The following is a description of a gene set: species: Homo sapiens Any process that modulates the frequency, rate or extent of a cellular response to stress. Cellular response to stress is a change in state or activity of a cell (in terms of movement, secretion, enzyme production, gene expression, etc.) as a result of a stimulus indicating the organism is under stress. The stress is usually, but not necessarily, exogenous (e.g. temperature, humidity, ionizing radiation). Human Gene Set: GOBP_REGULATION_OF_CELLULAR_RESPONSE_TO_STRESS, and this is the list of marker genes: DNAJC7, SLC38A2, RMI2, SPRED1, SYVN1, BRCA2, INSIG1, TIMELESS, SIRT6, SMARCD1, MDM2, HNRNPK, ANKRD1, SELENOS, PINK1, COMMD1, SEMA4C, FUT8, PTTG1IP, RAD52, POLH, RNF126, VPS72, ATXN3, PUM2, TEX15, NCK1, MTOR, PAGE4, TP53, PMAIP1, LRIG2, CD44, UFL1, ADCY8, DUSP10, MAP2K1, DDIAS, CD74, NR1H2, ARL6IP5, WAS, RTCA, BCL2L1, EPC2 (NCBI Gene Id 96643), TADA2B, TAF9, H2AX, ERP29 (NCBI Gene Id 10961), UBQLN1, PELI1, XRCC1, COPS3, MYC, PPP4R2, POT1, EP400, DYRK1A, PYHIN1, PNKP, INO80C, PRDX1, ACTL6B, PTN, TMX1, MBTPS2, LETM1, MRNIP, PIAS4, TAF6, THY1, RNFT1, RPA2, WRAP53, ATRIP, YBX3, PAQR3, EIF4G1, WFS1, SLF1, RNASEH2B (NCBI Gene Id 79621), PTGS2, NR1H3, HMGB1, CAV1, EYA4, BID, TIFAB, TERF2, CARD9, RNF8, NTRK3, TAF7, KAT5, TFPT, TAOK1, MAP3K20, MMP14, PPP4R3C (NCBI Gene Id 139420), KAT2A, DDX11, RNF168, STUB1, BCL7B, SKIL, BCL7C, ATAD5 (ATPase family AAA domain containing 5), SUPT20H, PRRX1, PLA2R1, MAGEA3, SMCHD1, ERCC6, FANCB, BRD7, CD36, ARID1A, FICD, UBQLN4, STK25, KIAA0319, SMARCC1, DNAJC2, ERN1, KDM1A, DEK, DNAJB6, PARP3, HELQ, FEM1B, FBH1, PML, TRIM28, ING3, SVIP, SHLD1, RECQL5, SERINC3, GSTP1, C11orf54, HDAC6, MID1, BDKRB2, MUC1, BAX, DPF3, ATXN3L, KMT5A, RPL26, SMARCD2, SETMAR, AMFR, PPP1R10, MIR199A1, CREB3, MEAF6, GCH1, SPIDR, SPP1, ATAD3A, PARK7, ZMPSTE24, DYRK3, FBXW7, CBX8, BAK1, RNFT2, COPS5, RUVBL2, POLQ (NCBI Gene Id 29043), TTI1, HERPUD1, ACTR5, CHEK1, INAVA, CUL4A, USP19, CERS2, TRIM32, TAOK2 (TAO kinase 2), ING2, TPT1, BCL2L12, PPP4R3B, INO80E, SMARCA2, PPP4C, AIFM2, BRD8, UBE2V1, ATF6B, INPP5F, KCNK2, ATXN7, ACTB, MGMT, CLN3, UBXN2A, RAD50, PIGBOS1, KLHDC10, MARCHF6-DT, WDR48, USP22, MAPK8IP2, NPM1, DDIT3, NUDT16L1, EEF1E1, HDGFL2, TAF2, TRIAP1, TAF4, TADA3, RIOX1, SUPT7L, TNR, EGFR, USP47, BABAM1 (NCBI Gene Id 29086), FADS2, TADA1 (transcriptional adaptor 1), CDK9, BFAR, NCK2, TP73, DPF1, RNF185, ZNHIT1, INO80D, MORF4L1, RFWD3, BRD4, DMAP1, ATXN7L3, DAB2IP, PARP1, EYA2, SPIRE1, EYA3, XBP1, GRINA, OXR1, MTCH2, MANF, FAS, FIGNL1, UIMC1, INO80B, MAPK1, SNAI2, TAF6L, ELL3, APP, SKP2, RIF1, NOL3, TFIP11, PBK, YJU2, NFE2L1, PPIA, AJUBA, PRMT1, DHX9, ARHGEF2, SOX4, ARID2, MAPT (microtubule associated protein tau), EIF2AK2, BOK, BABAM2, TIGAR, TELO2, EPO, SMARCC2, CCDC117, STK19, SCIMP, ADAM17, MRGBP, MARCHF7, VHL, FCGR2B, USP51, BMP7, HAPSTR1, ATM, HELB, CLU, ATR, CDKN2A, TWIST1, SUV39H1, BARD1, LPCAT3, PPP4R3A, UCHL5, CYREN, OOEP, MAPKAP1, DHFRP1, PPP1R15A, CHEK2, BAG6, SMARCE1, NOD2, MICU1, TOP2B, TRRAP (transformation/transcription domain associated protein), BBC3 (BCL2 binding component 3), ATF6, BCL2L11, TERF2IP (NCBI Gene Id 54386), NUPR1, IGBP1, UBXN1 (UBX domain protein 1), NACC2, SMARCB1, PBRM1, NSD2, SETD2, RTN4RL1, PIK3R1, FH, RTN4R, USP15, SETD7, MSX1, SLC25A23, BAD, MIR96, FUS, FOXO1, SGTA, TAF9B, PDCD10, RPS3, IER5, ABRAXAS1, CCAR2, SMARCD3 (NCBI Gene Id 6604), STK24, TLR4, HSF1, PTPRF, INO80, IKBKG, FMN2, TXNDC12, MAGEF1, PRKCG, FOXM1, PTPRS, NEO1, HYOU1, CREBRF, SHLD3, RTEL1, PARPBP, FBXO4, RAD9A, RGMA (NCBI Gene Id 56963), MEAK7, SCARF1, EYA1, TMEM259, OTUB1, NOD1, PLK1, STAT3 (NCBI Gene Id 6774), MIR221, RAD51, TAOK3, EGLN1, DDRGK1, FBLN5, PTPN2, ENO1, PNPLA8, YEATS4, ETAA1, USP13, KMT5C, ENY2, CNTF, BCAP31, NPAS2, SLC7A11, USP25, BCL7A, TAF5, PCNA, AQP11, TAF12, DNMT3A, KHDC3L (KH domain containing 3 like, subcortical maternal complex member), WDR76, RIPK2, OPRM1, GSK3B, C1QBP, ABCA7, DHFR, EPHA4, ARID1B, MIR21, CORO2B, DDAH1, YY1, BCL2, ACTR8, DRD2, ABL1, CEBPG, PIK3CB, MCRS1, NBN, TAF5L, TTI2, MAP2K2, UBQLN2, SENP3, DDX5, CREBBP, CSNK2A1, ZNF365, PRKN, MBTD1, NCOA7, AUNIP, KLF4, SF3B5, ALOX5, CGAS, NFE2L2, SPIRE2, ZBTB7B, BRAF, DPF2, GREM1, RACK1 (receptor for activated C kinase 1), KAT7 (lysine acetyltransferase 7), ROCK2, TGFB2, PRKDC, SUPT3H, FGF10, MIR132, TMED2, HSPA1A, IL26, CRY1, TBC1D24, BRCA1, MIR222, TMEM161A, NBR1, MAPKAPK2, HDAC10, SPRING1, SFRP2, TMBIM6, RAD51AP1, CXCL12, SMYD2, SPRED2, AGER, KREMEN1, MIR210, CHCHD2, RADX, ERCC8, SLF2, HMGA2, MRE11, HIC1, SMARCA4, USP1, PTPN1, DNAJB9, IGFBP6, EP300, GRN, ZNF385A, CRHBP, PARG, AKT1, CDKN2D, SF3B3, UBE2V2, MAPK3, EPC1, RNF183, PSMD10, BRCC3, MIR145, PHF10, AKT2, HSPA5, SNAI1, FAM168A, EIF2AK3, ABCD1, ACTL6A, KAT2B, ERCC1, AGR2, KDM4D, EFHD1, OGG1, CHORDC1, TAF10, UBE2N, DNAJB1, AKT3, AXIN2, ING4, CREB3L1, KLHL15, ERCC4 (NCBI Gene Id 7509), MAD2L2, TP53BP1, DNAJA1, OPA1, SLC25A14, SHLD2, IER3, MORF4L2, SGF29, KMT5B, FIGNL2, SIRT7, LRRK2, PPP1R15B, NFRKB, ACKR3, SIRT1, MIR431, RUVBL1, MIF, ACTR2 (actin related protein 2), PDX1, ZCWPW1, RNF169, QARS1, INSIG2, USP14, TMEM33